Given this list of marker genes Vmn1r201 (NCBI Gene Id 171255), Vmn1r49, Vmn1r43, Vmn1r226, Vmn1r227, Vmn1r74, Vmn1r4, Vmn1r22, Vmn1r45, Vmn1r216, Vmn1r193, Vmn1r214, Vmn1r217, Vmn1r81, Vmn1r9, Vmn1r30, Vmn1r89, Vmn1r24, Vmn1r188, Vmn1r73, Vmn1r206, Vmn1r47, Vmn1r19, Vmn1r203, Vmn1r213, V1ra8, Vmn1r212, Vmn1r27, Vmn1r67, Vmn1r229, Vmn1r84, Vmn1r235, Vmn1r200, Vmn1r190-ps (NCBI Gene Id 252908), Vmn1r205, Vmn1r232, Vmn1r237, Vmn1r83, Vmn1r220, Vmn1r40, Vmn1r195, Vmn1r230, Vmn1r54, Vmn1r78, Vmn1r28, Vmn1r236, Vmn1r50, Vmn1r66, Vmn1r218, Vmn1r222 (vomeronasal 1 receptor 222), Vmn1r80, Vmn1r197, Vmn1r8 (NCBI Gene Id 171205), Vmn1r228, Vmn1r192, Vmn1r211, Vmn1r210, Vmn1r41, Vmn1r199, Vmn1r231, Vmn1r37, Vmn1r46, Vmn1r52, Vmn1r32, Vmn1r208, Vmn1r33, Vmn1r36, Vmn1r26, Vmn1r23, Vmn2r116, Vmn1r233, Vmn1r202, Vmn1r215, Vmn1r21, Vmn1r16, Vmn1r5, Vmn1r7, Vmn1r51, Vmn1r75, Vmn1r38, Vmn1r70, Vmn1r219 (vomeronasal 1 receptor 219), Vmn1r17, Vmn1r76, Vmn1r35, Vmn1r234, Vmn1r196, Vmn1r87, Vmn1r48, Vmn1r191, Vmn1r6, Vmn1r44, Vmn1r225, Vmn1r185, Vmn1r189, Vmn1r82, Vmn1r198, V1rg10, Vmn1r18, Vmn1r42, Vmn1r53, here is a description of the gene set: Mouse Gene Set: GOMF_PHEROMONE_RECEPTOR_ACTIVITY Combining with a pheromone to initiate a change in cell activity. A pheromone is a substance used in olfactory communication between organisms of the same species eliciting a change in sexual or social behavior. species: Mus musculus